The following is a description of a gene set: The renal process that modulates the force with which blood travels through the circulatory system, by impeding blood flow through the peripheral vasculature. studied in species Mus musculus Mouse Gene Set: GOBP_RENAL_CONTROL_OF_PERIPHERAL_VASCULAR_RESISTANCE_INVOLVED_IN_REGULATION_OF_SYSTEMIC_ARTERIAL_BLOOD_PRESSURE, and this is the list of marker genes: Agtr1a (NCBI Gene Id 72294), Agtr2, Serpinf2, G6pdx, Agt, Mrgprd, Rhoa (NCBI Gene Id 51787), Cyp2j5, Mas1, Agtr1b